The following is a description of a gene set: studied in species Homo sapiens Human Gene Set: chr5q31, and this is the list of marker genes: PCDHA3, PCDHA5 (protocadherin alpha 5), SRA1, PCDHB5, PCDHGA2, ENSG00000238745, PCDHB17P, RPL12P21, SKP1, RNU6-1164P, SEPTIN8, TCF7, PCDHB19P, REEP2, ETF1, AFF4, STING1, ARAP3, PCDH1, PCDHB10, PURA, NR3C1, TRPC7-AS1, VTRNA1-2, RNU4-14P, PCDHB3, WDR55, HINT1, PCDHGA4, DDX46, FAM13B, RNU6-456P, ANKRD49P3, RPL6P15, HNRNPA1P13, GNPDA1, PCDHA11 (NCBI Gene Id 56138), TXNDC15, RPL36P11, ZMAT2, PCDHB15 (NCBI Gene Id 56121), TRPC7-AS2, MIR1289-2, PCDHB6, CYSTM1, HAUS1P1, TIFAB, PCDHB12, PCDHA7, IK (IK cytokine), SNORD63B, SLC35A4, SPRY4-AS1, MIR3661, IL13, RN7SKP64, IL5, BRD8, FSTL4, PCDHB1-AS1, PCDHGB5, ENSG00000200235, MTND3P25, KCTD16, ENSG00000251616, PCDHGB7, NAMPTP2, PCDHGB6, MTND4P12, ECSCR, SLC25A2, CTNNA1-AS1, RNU6-757P, PCBD2, PSD2-AS1, CTNNA1, C5orf15, MACROH2A1, EEF1A1P50, SNORA74D, SEC24A, CDC42SE2, RNF14, ENSG00000309135, PCDHB11, ZCCHC10, PCDHGB1, EGR1, NCOA4P4, DCANP1, PCDHB2, ANKHD1, FCHSD1, JADE2, KLHL3, FAM13B-AS1, EIF4EBP3, HNRNPA0, H3P25, RN7SL541P (RNA, 7SL, cytoplasmic 541, pseudogene), LINC01843, SNORD63, NDFIP1, WNT8A (NCBI Gene Id 83870), RNU6-460P, EPIST, SLC4A9, MATR3 (NCBI Gene Id 9782), ENSG00000293600, PCDHB1, WSPAR, PCDHB18P, NME5, RPL7P19, SLC25A48-AS1, PCDHGC3, SMAD5-AS1, APBB3, CXCL14, PCDHA14, ATP6V0E1P1, MIR6830, PCDHA9, DELE1, YIPF5, IL4, UBE2D2, PITX1-AS1, VDAC1, ACSL6, HSPA9, ARHGAP26-IT1, MZB1, PCDHGB2, PCDHA1, PCDHGA1, RN7SKP246, PCDHGA9, RNU5B-4P, SLC25A48, PCDHGA6, CDC23, CXXC5, NRG2, SAR1B, ANKHD1-EIF4EBP3, C5orf24, RPS27AP10, MIR5692C1, RNU6-888P, KIF20A, ARHGAP26-AS1, DNAJC18, RNA5SP195, RNU6-1311P, ACTBP4, IRF1, PCDHB9, PCDHA4, PAIP2, P4HA2, NPY6R, PITX1, RPL7P21, ENSG00000249639, KDM3B, RNA5SP193, TAF7 (TATA-box binding protein associated factor 7), PCDHB8, PCDHAC1, FBXL21P, GDF9, IL3, HARS1, MYOT, RNU7-156P, CDKN2AIPNL, MTND4LP30, P4HA2-AS1, HSPD1P18, ARHGAP26, PKD2L2-DT, CTB-1I21.1, PCDHB14, KIF3A, MIR874, PCDHGA3, PCDHGA11, AFF4-DT, DIAPH1, PCDHGC4, PSD2, PCDHGB9P, MIR5197, ENSG00000250378, SPRY4, LINC02900, PCDHAC2, NDUFA2, MTCYBP18, PPP2CA, PCDHB16, RELL2, MIR3655, HBEGF, RNU6-1148P, FGF1, RN7SL68P, PCDHGB8P, SMIM32, LRRTM2, CATSPER3, PCDHA10, SLC22A5, PCDHB13, MEIKIN, SNHG4 (small nucleolar RNA host gene 4), PCDHGA10, PCDHGB4, CARINH, MALINC1, CDKL3, SMAD5, LINC02863, PCDHB7, VTRNA2-1, CAMLG, SLC22A4, SNORA74A, PPP2CA-DT, MTND6P4 (MT-ND6 pseudogene 4), SHROOM1, HMHB1, MIR3936, PCDHA12, CD14, RNU6-572P, PCDHGC5, VTRNA1-3, CCNI2, PCDHA8, IGIP, SPOCK1, RPS12P10, HDAC3, TMCO6, TGFBI, PFDN1, GFRA3, PCDHGA7, FNIP1, HSPA4, IL9, MIR6831, RAD50, DND1, CSF2, LECT2, VTRNA1-1, TH2LCRR, PCDHGA5, PCDHA13, PCDHGB3, LEAP2, TRPC7, RNA5SP194, SMIM33, PCDHA2, RNU6-236P, HARS2, SPATA24, PCDHGA8, NEUROG1 (NCBI Gene Id 4762), UBE2B, PCDHB4, RNA5SP192, SOWAHA, ACSL6-AS1, PROB1, SIL1, FAM53C, LINC02999, RN7SL87P, MIR3936HG, SLC23A1, UQCRQ, ANKHD1-DT, PDLIM4, CDC25C, PKD2L2, PCDHGA12, PCDHA6, RAPGEF6, DIAPH1-AS1, CKS1BP5, MTND5P11, RPS27AP18, CXXC5-AS1, PCDH12